The following is a description of a gene set: Redundant skin studied in species Homo sapiens Human Gene Set: HP_REDUNDANT_SKIN Loose and sagging skin often associated with loss of skin elasticity., and this is the list of marker genes: ELN, MRPS22, CSPP1, ALG12, RFC2, NCF1, GTF2IRD1, FIG4, STX1A, MAP2K1, RAD21, VAC14, PRMT7, MAP2K2, RIN2, ENPP1, TRAF7, FGFR2, DNAJC30, VPS37D, SLC2A10, BRAF, SUZ12, PITX2, FGFR3, SH3PXD2B (NCBI Gene Id 57517), NSD1, RTL1, SLC25A24, EZH2, FGF20, TWIST2, DSE, B4GALT1, GTF2I, SEPTIN9, PYCR1, LIMK1, SLC6A8, GGCX, EFEMP2, CDK13, AEBP1, EBP, GTF2IRD2, PEX1, ANTXR1, NPR2, MRPS16, PIGA, PTDSS1, CD96, TBL2, ATP7A, FKBP6, TBX15, KIAA0586, ALDH18A1, HPGD, GORAB, TMEM270, COL3A1, BUD23, EXT1, LTBP1, NDUFB11, EIF4H, NAA10 (NCBI Gene Id 8260), LZTR1, DLK1 (delta like non-canonical Notch ligand 1), KRAS, HRAS, CHST14, ATP6V1E1, CLIP2, NDUFB10, ABCC6, ATP6V1A, METTL27, TRPS1, MEG3, ADAMTS2, FOXC1, CEP55, ATP6V0A2, GPX4, RPS6KA3, WDR37, H1-4, LTBP4, BAZ1B, WDR81 (WD repeat domain 81), FBLN5, OTUD5